The following is a description of a gene set: Signaling by FGFR studied in species Homo sapiens Human Gene Set: REACTOME_SIGNALING_BY_FGFR, and this is the list of marker genes: CBL, GTF2F2, SHC1 (NCBI Gene Id 6464), FGF16, SRC, FGFR1, PPP2CA, ESRP2, PIK3R1, POLR2C, POLR2K, FGF18, SPRY2, POLR2B, HNRNPM, TIA1, FGF5, HNRNPF, TIAL1, KRAS, FRS3, POLR2J, FGF22, FRS2, FGF4, GAB1, GIPC1, PIK3CA, GTF2F1, FGF1, FGF19, FGFBP1, KLB, NRAS, GALNT3, FGF10, PPP2CB, POLR2G, HNRNPA1, POLR2E, SPRED2, GRB2, SPRED1 (sprouty related EVH1 domain containing 1), HNRNPH1, KL, FLRT2, FGF20, FGFR3, MKNK1, RBFOX2, FGF17, POLR2H, UBA52, FGF2, PTBP1, FGFBP2, PLCG1, FLRT3, UBB, PPP2R1A, SOS1, FLRT1, FGF23, HRAS, NCBP1, FGFR2 (NCBI Gene Id 2263), POLR2D, UBC, POLR2F, FGFBP3, ESRP1, FGF6, FGF7, POLR2A, MAPK1, POLR2L, PTPN11, FGF9, BRAF, ANOS1, FGFR4, FGFRL1, FGF3, TGFBR3, MAPK3, POLR2I, FGF8, RPS27A, NCBP2